The following is a description of a gene set: species: Homo sapiens Reactome Pathway: Signaling by FGFR4 The 22 members of the fibroblast growth factor (FGF) family of growth factors mediate their cellular responses by binding to and activating the different isoforms encoded by the four receptor tyrosine kinases (RTKs) designated FGFR1, FGFR2, FGFR3 and FGFR4. These receptors are key regulators of several developmental processes in which cell fate and differentiation to various tissue lineages are determined. Unlike other growth factors, FGFs act in concert with heparin or heparan sulfate proteoglycan (HSPG) to activate FGFRs and to induce the pleiotropic responses that lead to the variety of cellular responses induced by this large family of growth factors. An alternative, FGF-independent, source of FGFR activation originates from the interaction with cell adhesion molecules, typically in the context of interactions on neural cell membranes and is crucial for neuronal survival and development.<br><br>Upon ligand binding, receptor dimers are formed and their intrinsic tyrosine kinase is activated causing phosphorylation of multiple tyrosine residues on the receptors. These then serve as docking sites for the recruitment of SH2 (src homology-2) or PTB (phosphotyrosine binding) domains of adaptors, docking proteins or signaling enzymes. Signaling complexes are assembled and recruited to the active receptors resulting in a cascade of phosphorylation events.<br><br>This leads to stimulation of intracellular signaling pathways that control cell proliferation, cell differentiation, cell migration, cell survival and cell shape, depending on the cell type or stage of maturation.<br> part of: Signaling by FGFR, and this is the list of marker genes: MAPK1, FGF19 (NCBI Gene Id 9965), PTPN11, FGFR4, NRAS, FGF4, SRC, PPP2CB, KRAS, PIK3R1, FGF16, FGF9, FGF6, UBA52, RPS27A, GRB2, BRAF, PIK3CA, SPRY2, UBB, FRS2, FGF20, GAB1, PLCG1, FGF1, MKNK1, HRAS, PPP2CA, KLB, CBL, SHC1, PPP2R1A, FRS3, FGF18, FGF23, SOS1, FGF2, FGF8, FGF17, MAPK3, UBC